Given this list of marker genes Sox9, Wnt2, Hmgb1, Six1, Ctnnb1, Wnt11, Chrd, Ihh, Fgfr1, Phf14, Myc, Tgfbr2, Foxp1, Zeb1, Gas1, Irs1, Fgf9, Prrx1, Pdgfa, Stat1, Shox2, Ptn, Isl1, Fgfr2, Fbxw4, Lmna, Tbx18, Shh, Mycn, Lrp6, Bmpr1a, Irs2, Kdr, Arhgap5, Foxp2, Bmp4, Wnt5a, Tbx1, Ctnnbip1, Lrp5, Foxf1, Prrx2 (NCBI Gene Id 20204), Smo, Nfib, here is a description of the gene set: studied in species Mus musculus Mouse Gene Set: GOBP_REGULATION_OF_MESENCHYMAL_CELL_PROLIFERATION Any process that modulates the frequency, rate or extent of mesenchymal cell proliferation. A mesenchymal cell is a cell that normally gives rise to other cells that are organized as three-dimensional masses, rather than sheets.